Given this list of marker genes HSPB1, RYR1, BAG3, MYH7, RPS27, FRG1, AAAS, FILIP1, HMGCR, ASH1L, DUX4, TIMM8A, MAP3K20, OBSL1, KBTBD13, RILPL1, RPS7, GDF11, PAX1, RPL11, TFG, POMT2, RPL26, ANO5, COL6A2, CHRND, TBX5, KANSL1, MYPN, PAX3, HARS1, TRIM2, CHRNE, RRM2B, TPM3, CEP126, SLC52A3, CYP7B1, LGI4, SVBP, PSAP, FLNA, LRIF1, ACTA1, SPTAN1, GALC, TRPV4, PLXND1 (plexin D1), SLC25A4, MYL2, OBSCN, GARS1, INF2, TRIO, NAA60, FBXW11, PYROXD1, GDAP1, PDK3, COLQ, SGCA, TIA1, CRPPA (NCBI Gene Id 730683), MT-CO1, CLDN11, LMNA, COL13A1, FHL1, COL6A3, TRIM32, CAV3, SMPX, TNNT1, DMD, MUSK, NEB, COL6A1, LPIN1, ALG14, DPAGT1, FKRP, NDRG1, POLG, TBX3, NOTCH2NLC (notch 2 N-terminal like C), VWA1, CHRNB1, GFPT1, JAG1, FGFR2, PRR12, DUX4L1, RPL18, BSCL2, RPL5 (ribosomal protein L5), GJB1, ALX3, TGFB3, SGCB, SPRED2, SALL4, MYMK, TSEN2, TWNK, MB, RPS29, CPOX, ALG2 (NCBI Gene Id 85365), RAPSN, MYOT, SIGMAR1, LAMA2, MYH2, SPTLC1, DNAJB6, CRYAB, PLEC, RPL15, MAP3K7, POGLUT1, TTN, MT-TE, GYG1, DNM2, PTPN11, MTPAP, RPS10, GBF1, DNM1L, KIF1A, COL12A1, ABHD5, TRAPPC11, LRP4, HSPB3, PLIN4, VPS37A, RPS20, CPLANE1, TSEN34, AGRN, GATA1, SYNE2, ITPR3, VCP, FLNC, REEP1, DOK7, LDB3, MFN2, HACD1, SMN2, MYF6, SBF2, CFL2, ANXA11, TMEM43 (transmembrane protein 43), EBF3, RPL35, FBXO38, RPL9, FLNB, CHRNA1, SELENON (NCBI Gene Id 7800), KIF5A, PRX (periaxin), SLC5A6, HK1, RBM8A, TRPS1, COQ7, FKTN, GMPPA, SPG7, HNRNPDL, EMD, RPS19, RPS15A, TSEN15, SPEG, HEATR3, BICD2, CUL7, FGD4, RPS26, CCDC8, CHCHD10, RAD51C, SEPSECS, DNA2, EMILIN1, FXN, LMX1B, SMCHD1, TSEN54, TNPO3, ADSS1 (adenylosuccinate synthase 1), IDUA (NCBI Gene Id 3425), GNB4, COMP, DYSF, C19orf12, BIN1, RPS17, ADA2, KCNJ2, SLC39A13, PPOX, KLHL9, STIM1, RPL31, HOXA13, EYA1, FBLN5, NEFH, MT-CO3, YARS1, TNR, ITPR1, CADM3, JAG2, TSR2, RYR3, ATP6V0A2 (NCBI Gene Id 7854), EIF4A3, SCN4A, RPL27, SLC12A6, MARS1, SNUPN, SLC25A21, PNPLA2, ALX1, POMT1, GMPPB, LIPE, OPA1, MPV17, SYNE1, ALS2, SCO2, SMN1, RPL35A (NCBI Gene Id 6165), ADAMTS15, PUS1, KY, MTMR14, MORC2, NGLY1, DCTN1, RPL8, NEFL (NCBI Gene Id 4747, neurofilament light chain), KAT6A, FBN1, WARS1, MYBPC1, AK9, TPM2, PMP22, RPS24, GIPC1, LRP12, PLOD3, REV3L, ITGA7, RAF1, SPG11, CAPN3, MPZ, BRAF, LAMB2, TCAP, CSGALNACT1, MYMX, KLHL41, HINT1, UBAP2L, DNMT3B, RTN2, TK2, SGCD, DSTYK, GNE, MATR3, SQSTM1, POLG2, HMBS, SEPTIN9, RPS28, SGCG, here is a description of the gene set: Human Gene Set: HP_ABNORMALITY_OF_THE_MUSCULATURE_OF_THE_UPPER_LIMBS Abnormality of the musculature of the upper limbs studied in species Homo sapiens